Given this list of marker genes KCNJ8, ITGB1, POMT2, GNAT2, POMGNT1, LARGE1 (NCBI Gene Id 9215), here is a description of the gene set: A neuroinflammatory response, occurring over several days, during which glial cells undergo nonspecific reactive changes in response to damage to the central nervous system (CNS); typically involves the proliferation or hypertrophy of different types of glial cells. studied in species Homo sapiens Human Gene Set: GOBP_REACTIVE_GLIOSIS